The following is a description of a gene set: Any process that stops, prevents or reduces the frequency, rate or extent of stem cell proliferation. studied in species Homo sapiens Human Gene Set: GOBP_NEGATIVE_REGULATION_OF_STEM_CELL_PROLIFERATION, and this is the list of marker genes: CEBPA, CD109, TP53, MIR222, GLI3, NFIB, OVOL2, KDF1, SNAI2, FERMT1, IRF6, WNT11, FGF10, FGF2, TSC22D1, FBLN1, OVOL1, NF1, MIR221, PTCH1, RARG, RBPJ, MIR16-1 (microRNA 16-1), MIR181A2, SFN, RARB, CDKN2C, MIR29B1